The following is a description of a gene set: from publication Amit I, Garber M, Chevrier N, Leite AP, Donner Y, Eisenhaure T, Guttman M, Grenier JK, Li W, Zuk O, Schubert LA, Birditt B, Shay T, Goren A, Zhang X, Smith Z, Deering R, McDonald RC, Cabili M, Bernstein BE, Rinn JL, Meissner A, Root DE, Hacohen N, Regev A (PMID 19729616) species: Homo sapiens Human Gene Set: GSE17721_CTRL_VS_LPS_8H_BMDC_UP Genes up-regulated in comparison of control dendritic cells (DC) at 8 h versus those stimulated with LPS (TLR4 agonist) at 8 h. mouse primary BMDCs were stimulated with tlr ligands and gene expression changes were profiled on Affymetrix arrays, and this is the list of marker genes: SRF, TMEM50B, MRPL42, TTYH2 (tweety family member 2), PBK, TRIM3, SMIM19, NUMB, UBE4B (ubiquitination factor E4B), GSTO1 (NCBI Gene Id 9446), RPL38, RBL2, IDH3A, PPIH, ZNF124, ATP6V0A2, KXD1, UPF3B, HDAC5, MAGED1 (MAGE family member D1), HTATIP2, NUP93, TRIM41, IMPA2, CIDEB, CIDEC, MRC1 (mannose receptor C-type 1), P2RX3, IFI30, CLIC1 (chloride intracellular channel 1), WDR45, ENTPD1, SLC30A5, ZFP91, LYSMD3, HMCES, ATRAID, TM9SF3, GCDH, NUP35, SEPTIN8, PUM3, REEP1, ELP2, TMEM51 (transmembrane protein 51), DIP2B, SLF2, TMEM141, RGS10, PALD1, HADH, ABCB8, OSBPL11, DUSP19, BRCC3, ELOVL6, KLRD1, ELP3, OPRL1, CDC25B (NCBI Gene Id 994), DCXR, TADA1, PHKG2, RAB31, STXBP2, EXT2, ZMYND19, HEBP1, RGS19, DGLUCY, MRPL55, B2M, NFAM1, LARS1, XPR1, CANX, COMMD6, LEPROT, LSM3, TECR (trans-2,3-enoyl-CoA reductase), MRPS26, SOCS6, FAM50A, NQO2, CENPQ, DPH7, IPO8, SPTBN1, MAP6, H2AX, RPS14, AKR7A2, SH3BGRL3, FAF1 (Fas associated factor 1), EIF3H, GCLM, SYT4, TMEM14C, SLC46A2, TDP1, PARVG, TFB2M, SALL3, SPO11, D2HGDH, FANCG, SUPT4H1, CERS2, RASSF2, TIMM10B (translocase of inner mitochondrial membrane 10B), ACOT13, PPP1R14B, MOGS, CENPV, CAPZA1, SLC25A46, CHCHD7, MCM7, MIDN (NCBI Gene Id 94034), ANKMY2, CDK4, PTPN18, FRRS1, HIP1, ERLIN1, MSL1, HACL1, ASGR2, ATP5PF, PTDSS2 (phosphatidylserine synthase 2), PDCD1, NAXE, RGL2, MDP1, LXN, PGRMC2, APOC2, NSF, TUBGCP3, SLC7A7, ALDH3A2, MKNK2, CPSF1, MAPK3, ESR1, QTRT1, RPL6, UBN1, SLC17A9, ZBTB11-AS1, SELENBP1, PNKD, CUEDC2, RNF181, TGFBI, DGCR6 (NCBI Gene Id 8214), RNH1 (ribonuclease/angiogenin inhibitor 1), GALNT2, METTL8, SLC25A4, GTF3C2, NEU1 (neuraminidase 1), NUDT4, CLTB, RETREG2, FAM117A, PIK3C2A, PNPLA7, CORO1A (NCBI Gene Id 11151), INPP5E, MTMR1, RNF5, PPP1CC, NSMF, FKBP4, LDLRAP1, LENEP, MED20, MINDY1, MANBA, FDPS, TK1, ADRB2, RAB40C, ALKBH4, HMGCL, OPHN1, FAM76B, RABGGTB, ATG3, OAZ2, OSBPL2, CD93, NAT9, ORC5, ADRA1A, DCPS, FAM162A, ERMP1, PIGB